The following is a description of a gene set: Any process that decreases the rate, frequency or extent of kidney development. Kidney development is the process whose specific outcome is the progression of the kidney over time, from its formation to the mature structure. The kidney is an organ that filters the blood and excretes the end products of body metabolism in the form of urine. species: Mus musculus Mouse Gene Set: GOBP_NEGATIVE_REGULATION_OF_KIDNEY_DEVELOPMENT, and this is the list of marker genes: Adipoq, Stat1, Osr1, Hnf1b, Bmp4